The following is a description of a gene set: species: Homo sapiens Infantile sensorineural hearing impairment A form of sensorineural hearing impairment with infantile onset. Human Gene Set: HP_INFANTILE_SENSORINEURAL_HEARING_IMPAIRMENT, and this is the list of marker genes: SETBP1, TK2, NDE1, PRG4, SARDH